Given this list of marker genes SLC33A1, SLC17A9, SLC35A5, LRRC8A, SLC35D1, SLC25A19, SLC35B1, ABCD1, SLC35D3, SLC35B2, SLC35A3, SLC35A4, ANKH, SLC25A42, PANX1, TMEM241, SLC25A16 (NCBI Gene Id 8034), SLC28A2, SLC25A26, ABCC4, SLC25A25, SLC25A24, SLC25A23, SLC19A1, SIDT1, SLC35C1, SLC25A32, SLC35B3, SLC29A2, SLC22A2, SLC25A51, SLC25A6, ABCC11, SLC35A2, SLC35E3, SLC25A33, SLC25A41 (NCBI Gene Id 284427), SLC25A52, SLC29A4, SLC25A4, ABCC5, SIDT2, SLC29A3, ABCD2, SLC35A1, SLC25A31, SLC25A47, SLC35D2, SLC29A1, SLC25A17, SLC25A36, SLC25A5, SLC35B4, SLC22A1, SLC25A53, SLC46A2, SLC28A1, SLC28A3, here is a description of the gene set: studied in species Homo sapiens Human Gene Set: GOMF_NUCLEOBASE_CONTAINING_COMPOUND_TRANSMEMBRANE_TRANSPORTER_ACTIVITY Enables the transfer of nucleobases, nucleosides, nucleotides and nucleic acids from one side of a membrane to the other.